Given this list of marker genes CSF1, TLR4, TREM2, STAP1, TLR2 (toll like receptor 2), PTPN2, here is a description of the gene set: Human Gene Set: GOBP_REGULATION_OF_RESPONSE_TO_MACROPHAGE_COLONY_STIMULATING_FACTOR species: Homo sapiens Any process that modulates the frequency, rate or extent of response to macrophage colony-stimulating factor.